The following is a description of a gene set: Elevated circulating long-chain acylcarnitine concentration studied in species Homo sapiens Concentration of long-chain acylcarnitine in the blood circulation above the upper limit of normal. Acylcarnitines are classified according to the number of carbon atoms in the acyl-chain. Long-chain acylcarnitines have between thirteen and twenty carbon atoms in the acyl-chain (C13-C20), Human Gene Set: HP_ELEVATED_CIRCULATING_LONG_CHAIN_ACYLCARNITINE_CONCENTRATION, and this is the list of marker genes: MCEE, LMBRD1, COX16, MMACHC, TANGO2